The following is a description of a gene set: Despite their enormous importance, the molecular circuits that control the differentiation of Th17 cells remain largely unknown. Recent studies have reconstructed regulatory networks in mammalian cells, but have focused on short-term responses and relied on perturbation approaches that cannot be applied to primary T cells. Here, we develop a systematic strategy – combining transcriptional profiling at high temporal resolution, novel computational algorithms, and innovative nanowire-based tools for performing gene perturbations in primary T cells – to derive and experimentally validate a temporal model of the dynamic regulatory network that controls Th17 differentiation. The network is arranged into two self-reinforcing and mutually antagonistic modules that either suppress or promote Th17 differentiation. The two modules contain 12 novel regulators with no previous implication in Th17 differentiation, which may be essential to maintain the appropriate balance of Th17 and other CD4+ T cell subsets. Overall, our study identifies and validates 39 regulatory factors that are embedded within a comprehensive temporal network and identifies novel drug targets and organizational principles for the differentiation of Th17 cells. from publication Yosef N, Shalek AK, Gaublomme JT, Jin H, Lee Y, Awasthi A, Wu C, Karwacz K, Xiao S, Jorgolli M, Gennert D, Satija R, Shakya A, Lu DY, Trombetta JJ, Pillai MR, Ratcliffe PJ, Coleman ML, Bix M, Tantin D, Park H, Kuchroo VK, Regev A (PMID 23467089) Human Gene Set: GSE43955_10H_VS_60H_ACT_CD4_TCELL_UP studied in species Homo sapiens Genes up-regulated in CD4 T helper cells Th0: 10h versus 60h., and this is the list of marker genes: ARAP3, SCAF11, GET3, ETFB, SOX10, FUBP1, MLST8, PRLR, ERCC1, PLEKHB2, NAGK, C1QB, GALM, ADRM1, IDH3B, ANAPC2, EPHX1, RABGGTA, ANXA5, EBF3, MS4A1, S100A8, FIBP, GLI1, RNASEH2C, TIAM2, TBL1XR1, MARCKS, RPL35A, ARL14EP, TRIM11, AP1M1, TBP, FPR2, RPA2, DHODH, MATN4, WDR26, ZHX1, DOK1, PPP1R1A, RBFOX2 (RNA binding fox-1 homolog 2), AGER, CEP350, GDI1, ADM, TRAIP, GRIK2 (glutamate ionotropic receptor kainate type subunit 2), KRT2, LY6H, NR2F6, ATP5F1C, GDPD3, DPP3, HARS1, SMC2, LY9, ALDH9A1, LY6G6C, C9orf72, P2RY1, GFER, PES1, NANS, GPR37, TIMM8A, LCN2, BATF, CRMP1, CYBA, CITED1, FGR, CNOT2, IL13RA2, MAP7D1, EGFL8, ALOX12, CD300C, ERGIC3, ATP6V1A, ZCCHC3, RGS10, SMARCA4, AFF4, BATF3, BARX1, DDAH2, ATP9A, SRP9, PLA2G1B, FHL1, RTN1, LSS, BRD8, PRKCSH, MRPS24 (NCBI Gene Id 64951), KCTD10, SGPL1, INTS3, BCKDHB (NCBI Gene Id 594), LSM14A, ISYNA1, MOGS, UQCR11, SHD, PROCR, HLA-DRB1, DNAJB1, CIITA (class II major histocompatibility complex transactivator), FAM20C, IFIT3, SUGT1, GLB1, ELP3 (elongator acetyltransferase complex subunit 3), ARPP19, C12orf57, MTREX, ATRX, AMACR, RUVBL1, SNX1, NAA38, EIF3D, VSX2, CRYZ, GMPPB, BCAR1, ISOC1, CYP4A22, EWSR1, TFPI, AQR, HIPK1, EYA2, FAM32A, PSMB8, PSENEN, APLP2, AADAC, ST6GALNAC4, AIRE, GKAP1 (G kinase anchoring protein 1), MPG, ATP5PF, GRWD1, CUX1, FAM50A, ITGA4, GPN3, F11R, PSMC3, SIX3, KRT6A, CD81, PHOX2A, LARS1, COMTD1, TRAPPC1, TBC1D22A, RS1, TLK2, HMGCR, PPP2R5A, CH25H, KCNB1, CAPZB, SSU72, ZNF22, PSPC1, PAN2, BCAS3, COPG1, NEU1, DMP1, CCT4, SART1, RRS1, FOXF1, RGL2, ACKR4, PLPP1, FOXK1 (forkhead box K1), TNIP1, DEAF1, DYNC1I1, ALDH2 (NCBI Gene Id 217), SQSTM1, BCAP31, MRPS18B, ITGB1BP1, CTSK, NUP54, PRDX1, NDE1, DCC, CD247, PHTF2, AKR1B15, TMEM222